Given this list of marker genes MED28P6, CTSH, GOLGA2P10, UBE2Q2P16, UBE2Q2P12, ARNT2-DT, IREB2, RNU6-1280P, RPL7L1P15, SAXO2, TM6SF1, SCAND2P, MIR4515, ZSCAN2-AS1, TUBAP4, UBE2Q2P6, GOLGA6L9-AS1, ZFAND6, TMC3, WDR73, AKAP13, ZNF592, MIR7706, MRPS11, CRABP1, AGBL1, PSMA4, AGBL1-AS1, RNU6-339P, RAMAC, ZSCAN2, RNA5SP400, LINC01584, FABP5P8, LINC02883, RNU1-77P, LINC00933, RNU6-380P, MIR1276, EFL1P1, CPEB1, SLC28A1, EFL1, MTHFS, AKAP13-AS1, LINC00927, CSPG4P12, UBE2Q2P11 (UBE2Q2 pseudogene 11), ENSG00000291211, CTXND1, MORF4L1, ENSG00000259636, UBE2Q2P2, SH2D7, FAH, MIR4514, FABP5P9 (NCBI Gene Id 91067), ADAMTS7, ANP32BP3, RN7SL331P, ENSG00000259620, LINC01418, GOLGA6L10, DNM1P51, BTBD1, CHRNA5, TFDP1P3, ANKRD34C, BCL2A1, DNAJA4-DT, NIFKP8, TMC3-AS1, ST20-AS1, ENSG00000288625, C15orf40, CEMIP, MEX3B, LINC01583, ALPK3, CSPG4P10, CSPG4P5, AP3B2, DNM1P38, MIR184, NTRK3, MRPL46, TBC1D2B, ACSBG1, IDH3A, RNU6-401P, SNORA63, ST20, SNHG21 (NCBI Gene Id 100505616), MINAR1, HYKK, RNU6-185P, RPS17, NTRK3-AS1, DNM1P41, WHAMM, ENSG00000259175, RNU6-796P, NMB, HOMER2, ARNT2, ENSG00000294083, GOLGA6L9, ENSG00000270919, RN7SL428P (NCBI Gene Id 106479379), RNU6-667P, RASGRF1, ADAMTSL3, MESD, CFAP161, CHRNA3 (NCBI Gene Id 1136), ANKRD34C-AS1, ADAMTS7P4, GOLGA6L4, SKIC8, RNU6-415P, MIR549A, PDE8A, ENSG00000177699, STARD5, UBE2Q2P1, EGLN1P1, ACTG1P17 (NCBI Gene Id 338963), RN7SL417P, GOLGA6L5P, LINC00052, ADAMTS7P1, SEC11A, GOLGA6L17P, KLHL25, CHRNB4, ST20-MTHFS, RNU6-1339P, RNU7-79P, HNRNPCP3, IL16, GOLGA6L3P, GOLGA6GP, GOLGA2P7 (GOLGA2 pseudogene 7, NCBI Gene Id 727994), TMED3, RPL21P116, ABHD17C, CIB2, MIR5572, HDGFL3, SH3GL3, RPL18P11, CPEB1-AS1, FSD2, BNC1, DNAJA4, MIR548AP, RNU6-231P, SCARNA15, TLNRD1 (talin rod domain containing 1), UBE2Q2P8, CSPG4P11, here is a description of the gene set: species: Homo sapiens Human Gene Set: chr15q25